The following is a description of a gene set: Nodules of heterotopia along the ventricular walls. There can be a single nodule or a large number of nodules, they can exist on either or both sides of the brain at any point along the higher ventricle margins, they can be small or large, single or multiple. studied in species Homo sapiens Human Gene Set: HP_PERIVENTRICULAR_NODULAR_HETEROTOPIA Periventricular nodular heterotopia, and this is the list of marker genes: VPS35L, ZSWIM6, ADGRL1, FAT4, ARFGEF2, MAP1B, ZMIZ1, ERMARD, FLNA, CPLANE1, DCHS1, INTS8 (NCBI Gene Id 55656), ZNF292, PRORP, TBC1D24, NEDD4L, ARF1, RNU4-2, CPLX1